Given this list of marker genes MT-CO3, MT-ATP6, MT-CYB, MT-ND6, MT-ND2, PRICKLE3, MT-ND4, MT-ND4L, MT-ND1, MT-ND5, here is a description of the gene set: Human Gene Set: HP_LEBER_OPTIC_ATROPHY Leber optic atrophy studied in species Homo sapiens Degeneration of retinal ganglion cells and their axons.